Given this list of marker genes Chac1, Pik3r1, Pla2g15, Hectd1, Cops7b, Plxna4, Man2a2, Nup210, Col12a1 (NCBI Gene Id 12816), Slc4a4, Klc4, Sall1, Dll4, Klf14, Sez6l, Stradb, Cdk17, Actr2, Drd1, Trabd2b, Cdca4, Znrf2, Kcnk10, Kcnj2, Csrnp1, Phc3, Qki, Apln, Colq (NCBI Gene Id 382864), Ythdc1, Lrig2, Cntnap1, Nfatc3, Ccdc85b, Tab3, Cdc37l1, Erc2, Adrb2, Kpna1, Spag7, Rreb1, Avl9, Krtap11-1, Armh4, Kif5c, Cpeb3, Ncapg2, Il7r, Il10ra, Arfgap2, Penk, Usp15, N4bp1, Ash1l, Gbp2b, Cbx4, Bace1, Kctd8, Xpo7, Ptpn3, Atg14, Adamts3, Gm12886, Prrc2c, Cmpk1, Tmem74b, Lhx3, Slc13a3, Med1, Zmym2, Ppp2r1b, Atf6, Atp7a, Kcnq5, Bcl2, Ccnjl, Kdsr, Cert1, Tmem87b, Tgfbr3, Kcnn4, Pip4p1 (NCBI Gene Id 219024), Chpt1 (NCBI Gene Id 212862), Fermt2, Sik1, Nup50, Phf19, Kif1b, Mfn2, Nynrin (NCBI Gene Id 97925), Capn6 (calpain 6), Htr4, Pnp2, Wbp11, Crebl2, Rictor, Eya1, Dsel, Pip4p2, Abtb2, Cldn12, Ttll6, Cfap45 (cilia and flagella associated protein 45), Dll1, Ippk, Phactr2, Phip, Smim13, Prdm4 (NCBI Gene Id 73308), Fmn2, Casr, Sgk1, Hapstr1, Syde2, Mapkap1, Tmem135, Ano3, Adgrl2, Zswim3 (NCBI Gene Id 97023), Garem1, Slc25a22, 6430571L13Rik, Anks1, Cbx6, Epha7, Bcl2l2, Tmem178b, Wipi2, Tbp, Stxbp3, Sema6d, Pappa2, B3gnt6, Plxna2, Kif1c, Ezh1, Rasef, Dcaf7, Rubcnl, Clspn, Hectd4, Ddx3x, Clock, Polr3f, Zyx, Entpd7, Itpr1 (inositol 1,4,5-trisphosphate receptor 1), Pam, Mmd, Ppp6c, Map2k1, Sptbn2, Tll1, Acvr2a, Axin2, Hoxa10, Nlrx1, Ankrd13b, Slitrk6, Ago1, Ankrd46, Ist1, Islr, Vegfa, Hephl1, Slc25a37, Kbtbd2, Atxn2, Rspo3 (R-spondin 3), Abhd13, Reck, Ptpn4, B4galt1, Abl2, Rab11fip1, Rfx3, Eif3a (eukaryotic translation initiation factor 3, subunit A), Raf1, Amotl1, Insyn2a, Myb, Pappa, Ski (NCBI Gene Id 99956), Smad7, Atp2b2, Krtap26-1, Rarb, Smurf1, Dclk1, Sema3a, Slit2, E2f7, Higd1a, Hus1, Aff4, Ret, Wfs1, 1700025G04Rik, Socs6, Cdk5r1, Nol4l, Ell, Wnt7a, Gpr63 (NCBI Gene Id 81006), Tfap2a, Nrbp1, Med26, Mybl1, Rad9a, Ccnd2, Angel1, Tacc1, Spryd3, Mob4, Septin2, Shoc2, Wnk3, Crebrf, Son, Gpatch8, Cacul1, Zfp300, Unc80, Ccne1, Ints6l, Tcaim, Rubcn, Seh1l, Slc7a2, Slc6a11, Ago4, Chek1, Fbxw7, Tlk1, Cd2ap, Arhgdia, Ubr3, Pacsin2, Usp25, Zbtb34, Traf3, Cbfa2t3, Cobll1, Bicd1, Zbtb39, Cc2d1b, Igf2r, Omg, Trank1, Onecut2, Pom121, Ccnt2, Rab9b, Fam135a, Ywhah, Pnpla6, Nudt4, Tbl1xr1, Cdk12, Rere, Ubn2, Slc39a10, Acvr2b, Etnk1, Tbpl1, Peli3, Kif23, Mgat4a (NCBI Gene Id 320137), Cpeb2, Lrrc32 (NCBI Gene Id 53807), Slc20a2, Caprin1, Pou2f1, G0s2, Plekhm3, Sec24a, Kmt2a, Grm7, Dcp1a, Ncs1, Zfp367, Btg2, Nudt7, Zfp773, Nos1, Usp42, Vtcn1, Cdc25a, Rnf217, Eda, Pex13, E2f3, Pwwp2b, Tenm2, Plekhh1, Pdxk, Akt3, Ppp1r11, Rab10, Dennd10, Plpp1, Rfc1, Usp31, Satb2, Sec61a1, Akap11, Ccr2, Ubfd1, Nrn1, Fgf9, Trp53inp2, Slc4a7, Ghr (growth hormone receptor), Prmt6, Zbtb44, Akap7, Extl3 (exostosin-like glycosyltransferase 3), Arl2, Fasn, Plagl1, Usp12, Plcxd2, Ppm1d, Pskh1, Iars1, Adgrl1, Arhgap12, Arih1, Rnf10 (ring finger protein 10), Rasgef1b, Lats1, Zfhx3, Nectin1, Nfe2l1 (nuclear factor, erythroid derived 2,-like 1), Cnot6l, Slc4a8, Cacna2d1, Nufip2, Helz, Selenoi, Sel1l3, Esp36, Tnrc6b, Scoc, Klhl2, Rnf144b, Rad23b, Sesn1, Zfhx4, Spred1, Plxnc1, Kif21a, Phf20, Zfp449, Tuba4a, Pnoc, Reln, Pafah1b1, Kif5b, Atp1b4, Suco, Jarid2, Pth, Sall4, Dnajc16, Zcchc3, Fbxo21, Acox1, Zfp622, Prkar2a, 2810459M11Rik, Gm5460, Gcc2, Ahcyl2, Adissp, Lrig1, Hmga1, Zfp809, Mex3c, Erlin2, Bmpr1a, Dync1li2, Nuak2, Lurap1l, Klc1, Wwp1, Ptprr, Acsl4, Fam151b, Chd2, Cpd, Dixdc1, Cyp26b1, Atxn1l, Btbd8, Srpra, Ppm1e, Nav1, Idh3a, Luzp1, Sec14l1, Fbln5, Kl, Capns1, Btrc, Cpsf7, Tmcc1, Wee1 (WEE 1 homolog 1 (S. pombe)), Lrp6, Usp14, Ccdc6, Setd3, Myt1l, Rbm6, Aar2, Ube2q1, Spsb4, Ube4b, Mob3b, Sox6, Atxn7l3, Fgf7, Armcx6, Wnt3a, Desi1, here is a description of the gene set: studied in species Mus musculus from publication Chen Y, Wang X (PMID 31504780) Genes predicted to be targets of miRBase v22 microRNA mmu_miR_195a_5p in miRDB v6.0 with MirTarget v4 prediction scores > 80 (high confidence targets). Mouse Gene Set: MIR_195A_5P